The following is a description of a gene set: from publication Yevshin I, Sharipov R, Kolmykov S, Kondrakhin Y, Kolpakov F (PMID 30445619) Mouse Gene Set: PML_TARGET_GENES Genes containing one or more binding sites for (Pml) in their promoter regions (TSS -1000,+100 bp) as identified by GTRD version 20.06 ChIP-seq harmonization. studied in species Mus musculus, and this is the list of marker genes: Pmf1, Gng2-ps1, mt-Th, Tcirg1, 1810034E14Rik, mt-Nd5, Gm24929, Bivm, Gm16231, Tent4b, Snrpf, Gm12933, Atp6v0d2, Prtg, Gm6921, Gm12354, Gm29605, Gm21083, Fli1, Poglut2, Neat1, Gm25897, Tm9sf4 (NCBI Gene Id 99237), Snord37, Mycl, mt-Tt, Arap1, Jph4, 1700028E10Rik, Plekhh3, Tns2, Aqp7, Gnat2, Elobl, Sgsm1, Rps15a-ps7, Adap2os, Cep128, Spo11, Gm15564, Sfi1, Clxn, mt-Ts2, Gm24120, mt-Tp, Hspb6, Gm14281, Vmn2r-ps20, Csnk1d, Sh3bp1, Ch25h, Rbms2, Frmd8os, Defb1, Tle6, Spata31e2, Cacng1, Slc2a10, Mink1, Lcn6, Cit, Gm13915, mt-Nd6, Psmg4, 6330549D23Rik, Lsg1, Mical2, Nat10, Glis3, mt-Tl2, Dgkq, 5430416N02Rik, BC034090, Rbm8a, A430034D21Rik, Gm8357, Mroh2a, Hormad1, Slc10a4, mt-Rnr2, Klc2, Rpl24, C030017G13Rik, Ankrd24, Ecscr, Mir6236, Hap1, Dpm2, Hnrnpab, Duxf1, Matn4, Gm43391, Speer4cos, Ncor1, Calcrl, Or8b39, Mtus1, mt-Tv, Tbc1d31, Gm19617, Diaph1, Gm14652, Cacna1s, mt-Te, Serpinb8, 4921536K21Rik, Gm9951, Gm2497, Rpl3, Srrt, Proser3